Given this list of marker genes Taf6, Gtf2a1, Tbpl1, Foxa2, Gtf2h3, Tbp, Taf2, Taf7l, Dr1, Taf5, Gtf2e1, Prrx2, Gtf2e2, Snapc4, Brf2, Gtf2b, Ccnh, Prrx1, Drap1, Taf11, Gtf2h4, Taf12, Gtf2f1, Snapc5, Taf1, Taf9b, Taf7, Taf9, Gtf2a2, Gtf2h2 (general transcription factor II H, polypeptide 2), Gtf2f2, Taf4 (NCBI Gene Id 98977), Taf10, Taf6l, Snapc2, Tbpl2, Taf4b, here is a description of the gene set: species: Mus musculus Mouse Gene Set: GOMF_RNA_POLYMERASE_II_GENERAL_TRANSCRIPTION_INITIATION_FACTOR_ACTIVITY A general transcription initiation factor activity that contributes to transcription start site selection and transcription initiation of genes transcribed by RNA polymerase II. The general transcription factors for RNA polymerase II include TFIIB, TFIID, TFIIE, TFIIF, TFIIH and TATA-binding protein (TBP). In most species, RNA polymerase II transcribes all messenger RNAs (mRNAs), most untranslated regulatory RNAs, the majority of the snoRNAs, four of the five snRNAs (U1, U2, U4, and U5), and other small noncoding RNAs. For some small RNAs there is variability between species as to whether it is transcribed by RNA polymerase II or RNA polymerase III. However there are also rare exceptions, such as Trypanosoma brucei, where RNA polymerase I transcribes certain mRNAs in addition to its normal role in rRNA transcription.